Given this list of marker genes FOSL2, SGCA, CD70, CHIT1, MLLT11, MYOG, KRT13, RBMY1A1, PTX3, SPTLC2, C3, ELMO1, RAB11B, CHGA, RXRA, CYBB, LGMN, MSLN, SCN4A, LNPEP, RRM2, HBB, HTR3A, GPX2, PCOLCE, TPSAB1, AKAP12 (NCBI Gene Id 9614), PTPRH, GPT, ENPP2, FYB1, KIF1A, KRT8, CD1C, UGT8, CHKA, RIN1 (NCBI Gene Id 9610), FGFR4, MKI67, LAD1, ADCYAP1R1, DELE1, MAN2A2, SLC1A6, POU3F1, ABCA4, UCK2, TK2, SDS, SECTM1, MYL2, DNM1, FOXO4, TPBG, PF4, MYH2, UCHL1, AKAP6, KRT7, XK, BLM, CCL5, NTN3, SOD3, SELENOP, SERPINB9, CD24, MUC1, CCL20, SPARC, ARHGAP22, INHA, SLPI, IRS1, THBS1, COX7A1, CAMP, ANK1, S100A3, MAPK4, MMP1, CLEC2B, NPRL3, TMEFF1, TNNI1, HAL, NTSR1, PLXNB1, FBLN2, NPAS1, CCNA1, TNFRSF1A, KIT, EPHA2, PRAME, CALD1, IFIT1, FURIN, FKBP1B (FKBP prolyl isomerase 1B), LMAN2, PMVK, MFAP2, SLC19A1, NEB, SCNN1B, NOS1, EVPL (NCBI Gene Id 2125), TNNT3, MAT1A, CCNE1, TNFAIP2, TNNT1, MAP7, MEST, CFHR1, FXYD2, ITGB7, JAK3, LPCAT3, ARHGDIG, ADM, TRIB2, PFN2, WT1-AS, TEAD4, MYL4 (NCBI Gene Id 4635), PPOX, LILRB4, PTPN3, CCL23, MMD, TGM3, CXCL12, ID4, GCH1, MAPK7, PSG6, RIMS3, HOXB7, MAOA, EMP1, MAPK10, ANPEP, KIR2DL4, DCAF7, TPM2, GLI2, KAT5, HOXA4, KLHDC3, PTK7, ATF2, SLC20A1, FRZB, UBE2H, ME3, WASHC5, DRP2, ITGA5, CACNA2D1, GRIK1 (NCBI Gene Id 2897), COMP, PDZK1IP1, KRT81, ZBTB48, AKR1C3, PRR4, TCEA2, SLC12A4, GCNT1, SPRR1B, CSRP2, DMAC2L, LIPA, P3H4, GABRB1, CD6, RAD9A, DUSP4, ELN, PMEL, TFF1, ITIH1, GTPBP1, PRPH2, FCN1 (ficolin 1), CLDN5, LST1, NGF, MARCKS, FAAH, APBA2 (NCBI Gene Id 9029), CACNG1 (calcium voltage-gated channel auxiliary subunit gamma 1), POMZP3, ST3GAL4, TCL1A, CTSL, ELF4, SHMT1, ASPH, PON2, PRRX1, STAB1, FUT4, GUCY1B1, ADH1A, NF2, PHLDA2, C8B, LRP1, PPBP, NFKBIL1 (NFKB inhibitor like 1), CEACAM1, LTB, GPR143, ETS1 (ETS proto-oncogene 1, transcription factor), TMSB15A, TCIRG1, P2RY14, IGFBP6, ITPKB, NKX2-1, RPS6KA2, KLF1, ACTA2, SERPINA7, CR2, ESRRA, HRK, GJA1, CFD, C3AR1, TFF3, BORCS8-MEF2B, CACNB3, KYAT1, PBX2, PTMS, GJB1, HK2, LSP1, EPB42, CPA1 (carboxypeptidase A1), HCAR3, BBC3, SMAD3, CD9, GDF15, RFC2, ITGA6, PTPRS, TCN2, KLK6, EPHA4, TAGLN, THRA, TNFAIP6, MAPK12, PKD1, PLCB3, CXCL10, KRTAP5-9, KCNQ2, COL6A1, AZGP1, SPOCK1, CPD, KRT18, SCNN1A, RPS4Y1, ACR, HNF1A, GLI1, CSH2, PAFAH1B3, PRB4, DTYMK, MMP9, TLE3, OPRK1, SLC7A6, EFTUD2, CCL17, SOD2, RXRG (NCBI Gene Id 6258), NFIX, MYL9, GATA2, PDGFRA, DSG2, NKX3-1, ERBB2, KCNMB1, C5AR1, PRSS8, CORO1A, HMGCS1, STS, H2AC6, ZFP36L2, EPOR, CD79B, KLF4, MX1, CDC42EP1, BCL6, MAPK11, RORA, RUNX1, RAPSN, C7, HCK, HSPG2, PLOD2, MYL1, PTAFR, CD36, INPP1 (NCBI Gene Id 3628), KCNH2, PFKFB3 (NCBI Gene Id 5209), MYH7, TSPAN7, ELF3 (NCBI Gene Id 2106), ADIRF, CRYM, MAPK8IP2, ASS1, ADARB1, FEZ1, RGS3, ASAH1, CTSH, PDCD1, FABP4, CCDC106, NRG1, ACP5, ARC, CLC, FAT1, CNR2, ERF, BPI, LTBP1, GSTM5, SELL, TP53I11, GHRHR, CAPG, SPOCK2, EPAS1, LGALS3BP, PTH1R, NAB2, KCNAB2, LY6D, KRT4, SLC28A1 (solute carrier family 28 member 1, NCBI Gene Id 9154), KMT2A, CCL21 (C-C motif chemokine ligand 21), GLRA2, CLEC10A, KDM5D, PPP5C, ARL4A, BLK, DEFB4A, RAC2, PTN, ART3, TLE1, KRT5, TESK1, CD247, CNTNAP1, ALOX15, MERTK, VWF, IL1R1, CD27, BIK, KIAA0040, INPP5A, here is a description of the gene set: Human Gene Set: MODULE_33 Immune / stress response genes. species: Homo sapiens